The following is a description of a gene set: Human Gene Set: REACTOME_NUCLEOTIDE_SALVAGE species: Homo sapiens Nucleotide salvage, and this is the list of marker genes: AMPD1, UPP1, ADA, ADK, PNP, UCKL1, HPRT1, TK1, GMPR, UCK1 (uridine-cytidine kinase 1), AMPD3, PUDP, TK2, MAPDA, UPP2, UCK2, GMPR2, TYMP, CDA (cytidine deaminase), AMPD2, DGUOK, APRT, DCK